The following is a description of a gene set: species: Homo sapiens Metaphyseal cupping refers to an inward bulging of the metaphyseal profile giving the metaphysis a cup-like appearance. Human Gene Set: HP_METAPHYSEAL_CUPPING Metaphyseal cupping, and this is the list of marker genes: LBR, PEX5, PCYT1A, PAM16 (NCBI Gene Id 51025), MMP13, IDH1, INPPL1 (inositol polyphosphate phosphatase like 1), PTH1R, CYP3A4 (cytochrome P450 family 3 subfamily A member 4), HDAC6, TRIP11, GPX4, COL2A1, NEPRO, CYP27B1, RMRP (RNA component of mitochondrial RNA processing endoribonuclease), COL11A2, AIFM1, ALPL, COL10A1